The following is a description of a gene set: part of: Cellular response to chemical stress Reactome Pathway: Cytoprotection by HMOX1 This event has been computationally inferred from an event that has been demonstrated in another species.<p>The inference is based on the homology mapping from PANTHER. Briefly, reactions for which all involved PhysicalEntities (in input, output and catalyst) have a mapped orthologue/paralogue (for complexes at least 75% of components must have a mapping) are inferred to the other species. studied in species Mus musculus electronically inferred by orthology from the curated human pathway, and this is the list of marker genes: Cox6a1, Cox8c, Alb, Cox5a, Hmox2, Sin3a, Cox7a2l, Cox8a, Carm1, Cox6c, Ncoa1, Cox4i1, Helz2, Cycs, Med1, Hdac3, Ncor2, Hbb-bt, Cox7c, Cox4i2 (NCBI Gene Id 84682), Tbl1x, Higd1c, Cox7a1, Cox6a2, Blvrb, Ndufa4